Given this list of marker genes GAS6, COL18A1, KCNK1, ENPEP, ENG, ADIPOR2, HGD (homogentisate 1,2-dioxygenase), TUT7, RAB33A (NCBI Gene Id 9363), ZNF862, AQP9, ECM1, RASGRF1, SULT1B1, VSTM4, LAMA3, BLOC1S1, HPD, LDB2, CYP2E1, RCAN1, AR, ALDH2, PLXNB2, IGF1, UGT2B4, SPON1, GHR, MYLK, C8A, LAMA2, BSCL2, DAPK1, ENTREP1, IL6ST, VEGFD, DBP, CYP2B6, ADH6, AOX1, TRAK1, EGR1, TFAP2A, NFKBIA, CTSF, FRY, MYCL, RAMP3, ANXA4, LMOD1, SLCO1B3, RARRES2, CAPN2, SPTBN1, HDAC9, PREB, BHLHE40, ITM2A, CDC42EP3, DNASE1L3, DEPDC5, CD81 (NCBI Gene Id 975), TK2, AADAC, ITGA8 (integrin subunit alpha 8), TSC22D1, ZEB1 (NCBI Gene Id 6935), PHYH, SMAD7, SNRK, CYLD, SERPING1, UBA7, PON1, PEBP1, ACSL5, SGCB, JADE2, KDM2A, ITIH5, ZBTB20, MFAP3L, LCK, FAS, CAMK1D, PSME2, NAP1L1, AMOTL2, TTC9, HOMER2, KIAA0040, LIMS2, SLCO1B1, GATM, CAT, CYP2C9, ABCA2, CASP4, C1R, IL2RB, NTF3, HSD17B6, TRADD, KLRB1, GC, APOC4, MAP3K14 (mitogen-activated protein kinase kinase kinase 14), P4HTM, PALM2AKAP2, PACRG, CTSO, APBB3, SLC6A1, LPXN (leupaxin, NCBI Gene Id 9404), PEA15, TRIM22, BLNK, ST3GAL5, ZCCHC24, ZNF710-AS1, ITIH4, ATP10A, WFDC1, FABP3, SGPL1, DCN, ADH1A, FMO3, ABHD6, ADH1C, ZSWIM8, ANXA10, FAT4, EMCN, MMRN2, ARL6IP5, B2M (NCBI Gene Id 567), IL1R1, BCL6, TRANK1, ALDH3A2, TJP1, BLCAP, GABARAPL1, SLC30A1, CTXND1, KLRK1, MYRIP, C1S, GLUL, COPZ2, UQCRQ, MTMR11, SMAD3, RARB, SVEP1, MAP3K5 (NCBI Gene Id 4217), ATN1, SHB, MICU1, CSRP2, GIMAP5, MAST4, NAXD, SNED1, C1QTNF3, SLC27A5, MYL12B, ADH1B, NR1D2, TBC1D2B, HSPB6, HIVEP2, ALAS1, ADIRF, ASPA, RPS27L, APCS, PDE2A, ZBTB18, KHK, TST, CD59, KANK3, PAMR1, PTPRB, HCP5, HSD11B1, SYNPO, GLYAT, SLC10A1, DKK3, TNS2, SLC4A4, GFOD1, CD5L, C7, GPR171, RRAS, FMO4 (NCBI Gene Id 2329), AFM, WASHC3 (NCBI Gene Id 51019), CX3CR1, DAO, ABCA6, PLA2G4C, NBL1, CYP1A1, KANK2, RBP1, TSC22D3, HTRA1, PRKCH, here is a description of the gene set: studied in species Homo sapiens from publication Cairo S, Armengol C, De Reyniès A, Wei Y, Thomas E, Renard CA, Goga A, Balakrishnan A, Semeraro M, Gresh L, Pontoglio M, Strick-Marchand H, Levillayer F, Nouet Y, Rickman D, Gauthier F, Branchereau S, Brugières L, Laithier V, Bouvier R, Boman F, Basso G, Michiels JF, Hofman P, Arbez-Gindre F, Jouan H, Rousselet-Chapeau MC, Berrebi D, Marcellin L, Plenat F, Zachar D, Joubert M, Selves J, Pasquier D, Bioulac-Sage P, Grotzer M, Childs M, Fabre M, Buendia MA (PMID 19061838) Human Gene Set: CAIRO_HEPATOBLASTOMA_CLASSES_DN Genes down-regulated in robust Cluster 2 (rC2) of hepatoblastoma samples compared to those in the robust Cluster 1 (rC1). Hepatoblastoma, the most common pediatric liver cancer, is tightly linked to excessive Wnt/beta-catenin signaling. Here, we used microarray analysis to identify two tumor subclasses resembling distinct phases of liver development and a discriminating 16-gene signature. beta-catenin activated different transcriptional programs in the two tumor types, with distinctive expression of hepatic stem/progenitor markers in immature tumors. This highly proliferating subclass was typified by gains of chromosomes 8q and 2p and upregulated Myc signaling. Myc-induced hepatoblastoma-like tumors in mice strikingly resembled the human immature subtype, and Myc downregulation in hepatoblastoma cells impaired tumorigenesis in vivo. Remarkably, the 16-gene signature discriminated invasive and metastatic hepatoblastomas and predicted prognosis with high accuracy.